The following is a description of a gene set: Reactome Pathway: Defective Intrinsic Pathway for Apoptosis Due to p14ARF Loss of Function Cancer-derived missense mutations in the CDKN2A gene that affect the C-terminal arginine-rich region of p14ARF (also known as CDKN2A transcription isoform 4, CDKN2A-4, p14 or ARF) impair p14ARF binding to the mitochondrial matrix protein C1QBP and interfere with p53-mediated apoptosis. Many mutations in the CDKN2A locus that affect C-terminal arginines of p14ARF are silent in p16INK4A (CDKN2A-1). part of: Defective Intrinsic Pathway for Apoptosis species: Homo sapiens, and this is the list of marker genes: C1QBP, CDKN2A